The following is a description of a gene set: studied in species Mus musculus A spliceosomal complex that is formed by the displacement of the two snRNPs from the precatalytic spliceosome; three snRNPs including U5 remain associated with the mRNA. This complex, sometimes called the activated spliceosome, is the catalytically active form of the spliceosome, and includes many proteins in addition to those found in the associated snRNPs. Mouse Gene Set: GOCC_CATALYTIC_STEP_1_SPLICEOSOME, and this is the list of marker genes: Eif4a3l2, Tex16, Cwc25, Cwc22rt5, Yju2, Rbm8a, Cwc22rt3, Magohb, Snrnp200, Casc3, Isy1, Rbm8a2, Cwc22rt6, Cwc22rt7, Eif4a3, Prpf19, Cwc22rt4, Eif4a3l1 (eukaryotic translation initiation factor 4A3 like 1), Rbm22 (RNA binding motif protein 22), Cwc22rt1, Cwc22, Prpf8, Cwc22rt2